The following is a description of a gene set: Mouse Gene Set: GOBP_TRANSPOSABLE_ELEMENT_SILENCING_BY_PIRNA_MEDIATED_HETEROCHROMATIN_FORMATION studied in species Mus musculus A transposable element silencing mechanism in which a Piwi-associated RNA (piRNA) triggers heterochromatin assembly. Heterochromatin is a chromatin conformation that is refractory to transcription., and this is the list of marker genes: Ddx4, Piwil2, Spocd1, Tdrd9, Piwil1